The following is a description of a gene set: Human Gene Set: HP_BROAD_DISTAL_PHALANX_OF_FINGER Abnormally wide (broad) distal phalanx of finger. studied in species Homo sapiens Broad distal phalanx of finger, and this is the list of marker genes: CREBBP, EXOSC2, CHST3, WLS, WDR19, RNU4ATAC (RNA, U4atac small nuclear), HOXD13, IFT122, GNAS, B3GAT3, FBXO11, KIF22, SETD5, FLNB, MEG3, SMARCA2, BGN, AMMECR1, HS2ST1, FLNA, GATAD2B, FGFR2, DLK1, B3GALT6 (NCBI Gene Id 126792), EP300, GPC4, RTL1